The following is a description of a gene set: Abnormal circulating lactate dehydrogenase concentration studied in species Homo sapiens Human Gene Set: HP_ABNORMAL_CIRCULATING_LACTATE_DEHYDROGENASE_CONCENTRATION A deviation from the normal serum concentration/activity of lactate dehydrogenase (LDH), which catalyzes the reduction of pyruvate to form lactate., and this is the list of marker genes: LDHA, CDAN1, SLC7A7, LDHB, KY, RB1, LYST, LARGE1, OBSCN (NCBI Gene Id 84033), IRAK1, PLA2G6, TCIRG1, DAG1, PFKM, ZNFX1, AIFM1, HMGCS2 (3-hydroxy-3-methylglutaryl-CoA synthase 2), PITRM1, MT-CO3, TOMM7, CBLIF, ACAD9, LIN28B, VPS13A, MLIP, BCL2, JAK2, MYC, PLEC, POMK, GATA1, HBB, USB1, MPL, POMT2, SLC19A1, SLC4A1, BCL6, FLI1, SLC25A13, RPS14, SPP1, MVK, CHEK2, PHOX2B, HMOX1, COL4A1, B4GAT1, RHAG, POMGNT2, RXYLT1, DHFR, KIF23, FKRP, PSMB9, CFH, CALR, POMT1, PNPLA2, KCNN4, RHCE, ALDOA, OCRL, LPIN1, MTHFD1, CD46, HACE1, MYCN, LMO1, CAV3, NSUN2, SIL1, PIK3CG, ALK, PEX2, POMGNT1, MT-CO1, FKTN, HELLPAR, GAA, ACADM, CPT2, SAT1, STAT4, TP53, AKR1D1, KLF1, TET2, XK, CFI, PIGA, CRPPA, PIEZO1, B3GALNT2, RHD, STIM1, GCLC, LIPA, ABCG8, HLA-DRB1